The following is a description of a gene set: Human Gene Set: GOBP_NEGATIVE_REGULATION_OF_DEFENSE_RESPONSE_TO_BACTERIUM Any process that stops, prevents or reduces the frequency, rate or extent of defense response to bacterium. species: Homo sapiens, and this is the list of marker genes: MAPKBP1, ARG2, SPINK5, HAVCR2, MIR181B1